The following is a description of a gene set: Human Gene Set: REACTOME_PURINERGIC_SIGNALING_IN_LEISHMANIASIS_INFECTION studied in species Homo sapiens Purinergic signaling in leishmaniasis infection, and this is the list of marker genes: RELA, PYCARD, TXNIP, NLRP3, IL1A, NFKB1, PSTPIP1, IL1B, HSP90AB1, CTSG, P2RX7, NT5E, GSDMD, SUGT1, APP (NCBI Gene Id 351), C3, HMOX1, NFKB2, TXN, ENTPD5, IL18, MEFV (MEFV innate immunity regulator, pyrin), P2RX4, CASP1, ENTPD1, C3AR1